Given this list of marker genes DEXI, SOSTDC1, ANKRD13B, LINC03020, CPLANE2, SELENOM, EPS15, MARCHF3, FGD5P1, ITGB1, SEMA3B-AS1, TSC22D1, ZYG11B, RPS6KA1, HMGB1P28, EIF2AK3-DT, CHAC1, B4GALNT1, JMJD4, EPHX1, ENSG00000187951, ALKBH5 (alkB homolog 5, RNA demethylase), MIDEAS, HNRNPH3, MPP2, SLC25A28, SPSB1, NAV1, USP35, TMEM164, MIR22HG, PRCC, NFIX, INPP5A, DOCK7, ARPIN-AP3S2, TNK2, TMEM74, MINDY2, RFPL1S, NEDD4L, AGA, COPS7A, RAN, ZFTA, SP3, POLA1, VASN, CHP1, TMT1A, COLGALT1, USP10 (NCBI Gene Id 9100), LEPROT, WDR5, CCNG2, GATA3-AS1, CNOT10, KCTD11, SEC1P, PRICKLE1, RRAGB, IQCF5-AS1, SLC29A4, NUCB2, SERTAD3, MOCOS, BACE2, WWC2-AS1, DIO1, WFDC21P, EHMT2, TCP10L, LMO2, CYTH1, E2F3, PDIK1L, NBPF11, LINC02391, GALE, SDAD1P1, TMEM145, UGGT2, LETMD1, ZNF76, CCL24, CDIPT, LARP1, MYO9A, GP9, PTGES2 (NCBI Gene Id 80142), VSTM2L, TK2, EIF2AK3, CALR, GFI1B, TELO2, FAM13A, SHB, BSG, ARHGAP33, S100A16, DONSON, PROSER2, ERRFI1-DT, SUB1, PHOSPHO1, TMEM245, FGGY, ANO5, ENSG00000266976, KCNN1, UTS2B, HAUS2, PYM1, EFCAB7, KTN1-AS1, MACF1, PARD3B, NKILA, MKLN1-AS, ZNF44 (zinc finger protein 44), PFDN4, AP3B2, TMEM140, IER2, ZNF628-DT, EPM2A-DT, RNF227, C2, SLC25A22, AKR1B1, PICART1, TCN2, MMAA (metabolism of cobalamin associated A), MCUR1, SULT2B1, DOK4, KLC4, FBXO2, DGKA, FAM222A-AS1, DPF3, CACNG7, UBALD1, TMEM167A, ENSG00000233230, MRAS, ZNF256, TEX2, TM2D1, TFDP1, ZSCAN5A-AS1, ZBTB7A, GHDC, REM2, NCS1, GAL3ST1, DUSP7, VAT1, ASCC2, UBASH3B, B4GALT5, PEX19, ITPK1, DHRS12, SLC25A28-DT, SPPL2A, MIEF2, MAP3K12, ZNF548, TYW1, CCN1, METTL26, SLC6A9, SPN, TNFRSF12A, PHLDA1-DT, MAP3K7, MBOAT7, SREBF1, CLDN5, INTS6-AS1, EFHD1, COX10, CD2BP2, RNF44, TBKBP1, EP400P1, ZFAND3, POGK, ENSG00000267288, SBDS, KPNA6, FBXO11, TAL1, TLE4, SDSL, KIAA0930, CKLF, POC1A, CTNNBIP1, SLC39A8, MRPL55, CHRNA1, ATXN7L1, TMC6, SARDH, AP4M1, ILVBL, USP36, BPIFB6, INKA2-AS1, RBMS2, RBM39, ADCK1, PALD1, BPNT2, SLC35D1, C5AR1, SURF4, NPY1R, DMAC2, ASH2L, TNRC18, OTOG, KTN1, BTF3L4 (basic transcription factor 3 like 4), HIPK2, ASL, RYK, SNX32, IQANK1, ERICH6, ENSG00000283573, ETFBKMT, POLR1G (RNA polymerase I subunit G), ADRA1A, C19orf25, ADRB3, SQSTM1, TMED1 (NCBI Gene Id 11018), RGS16, HIVEP3, SUPT7L, TMUB2, FBRS, YJU2B, SATB2, SMG1P2, IRGQ, B2M, SUGCT, ENDOG, GNB1 (NCBI Gene Id 87729), IKBKB, PUSL1, FNIP2, CHD4, PPP1R13L (NCBI Gene Id 23453), MMP17, EPB41, PAPOLA, RPSAP71, YRDC, CYP27B1, NKD2, KLK8, HES1 (NCBI Gene Id 3280), ETF1, HDGF, KLHL5, FAM182B, EXPH5, PPP1R14B-AS1, PIK3C3, PAFAH1B2, TATDN1, NAV3, SYTL4, ACTL6B, ARHGEF12, DLG3 (NCBI Gene Id 89363), SLC26A6, CS, ZNF416, ZKSCAN8P1, CCDC28B, ZNF524, POLI, FUNDC1, OR52A4P, RNA5SP319, ZNF703, MVP, LSM12, CRYGEP, CYP4B1, INCA1 (inhibitor of CDK, cyclin A1 interacting protein 1), GAN, GALNT11, RFT1, HES2, ADPRHL1, LIM2-AS1, SLC4A11, AXL, PLD1, MAPK8IP1, ENSG00000266088, SEC22C, CYRIB, VASP, RTN4IP1, PJVK, OSBPL5, ENTPD7, ASAP2, RNASET2, DUS1L, TMEM184B, LINC02405, NUMA1 (NCBI Gene Id 4926), SAXO5, PLBD2, OTUD7A, LINC01825, XIST (X inactive specific transcript), ZFP91-CNTF, MIF, VPS37D, WDR5-DT, SPACA6-AS1, NFIB, C10orf88, LINC02573, SLC25A23, TAF6L, MAGI1, PCGF6, RGS10, MRPL39, YARS1, DSTYK, TWSG1-DT, ACAP3 (ArfGAP with coiled-coil, ankyrin repeat and PH domains 3), SLC25A46, TMEM120B, SPATA41, BAZ2A, DNAJC8, TMEM236, TMEM119, MICAL3, MKI67, CFP, RNASEK, ETHE1, OTUB2, VAMP4, AHCYL2, ROBO1, USP45, IFT43, ANKRD10, ZFP69, NBAS, SHKBP1, HCFC1, CIRBP, ARHGEF19, GIT1, ANKMY1, MAMLD1, RPS6KL1, NFATC4, IGKV6D-41, C1orf122, ERCC1, CECR7, SNED1, RPL10P8, LINC01366, MSH5-SAPCD1, DNAH9, RPL12, PRPH (NCBI Gene Id 5630), AMER1, NKX3-2, ASB16-AS1, ANLN, ZNF547, TMEM160, TUBAP14, MRPL44, POC1B, GNB4, AGA-DT, ZFAND6 (zinc finger AN1-type containing 6), RNPS1, IQCH-AS1, PAN3-AS1, GJD3, FLNA, ITPRIPL2, MAPRE2, FAM234B, NFIA, SEPHS2, MORC2, EEF1A1P7, GIT2, GPAM, IFT81, NPM3, MKNK1 (NCBI Gene Id 8569), RND1, ZKSCAN3, FBXO5, GMFB, VASH1-DT, CYP19A1, LINC01625, LMAN2L, LINC00540 (long intergenic non-protein coding RNA 540), RBM44, DNAJB1, ATG2A, TCF7, SUCLG2, CASP8, LINC02028, ZNF792, ATOH1, TRAPPC2B, RPL23AP53, ZNF436-AS1, AACS, UBE2F-SCLY, C2orf92, MIR550B1, RPL17P41 (ribosomal protein L17 pseudogene 41), IKBKB-DT, RTCA, DAGLB, STX5-DT, SH3BGR, MRTFB, GIPC1, NEK6, XPR1 (xenotropic and polytropic retrovirus receptor 1), JPH4, FBXO9, SLC25A12, FKBP8, EBI3, RFNG, PICALM, CACNA1A, CSPG4, AHDC1, DPP9, MIR3677HG, MAPKAPK2, EGFEM1P, EMSY (EMSY transcriptional repressor, BRCA2 interacting), PMEPA1, LRFN3, EEF1AKMT3, RIC8A, XRCC4, ADNP, KDELR2, CRADD-AS1, MCEMP1, TKT, CAMKK2, KDM4C, BPTF (bromodomain PHD finger transcription factor), TRA2A, DNAJB5-DT, MEF2D, GCN1, ANO10, ATXN2, MVP-DT, DNAJC16, ZNF596, EWSR1, STX3, LRRC23, CBLN1, ACTN2, TRAPPC8 (NCBI Gene Id 373175), SSR4P1, ECT2, MIA2, HEXIM1, BTBD2, FAM131A, TXNDC17, CKAP5, ACBD3-AS1, SLC25A53, METAP1 (methionyl aminopeptidase 1), FLII, FCHO1, PITX1, TOM1L2, KIF6, RAB11A, RPL21, GOLGA3, NRL, SLC16A3, MRPS17, TMEM198B, FAM149A (family with sequence similarity 149 member A), ZNF48, YIPF1, MKLN1, HDLBP, TEN1-CDK3, TAOK3, KSR1, SLC9A9, TUBAL3, ZNF623, MRPL42P1, PSME4, ERVV-2, BRD3OS, CHPF, LINC02593, BBS10, USP2, IER5, RPL29P34, DCUN1D2, MEIS3, CDC14A, RPP14, C19orf73, CSF2RB, SPRY1, ADORA1, UBAP2L, TRAF3IP2-AS1, UNC13A, CRELD1 (cysteine rich with EGF like domains 1), DIPK2A, KDM6B, ABCA7, NOS2P4, LINC02926, DUSP8, KCTD21, TMEM39B, MCRIP2, RPL7A, ADARB1 (adenosine deaminase RNA specific B1), DNAJC6, BAZ1B, CASTOR1, LINC00690, ANP32E, BICRA, PROSER2-AS1, MARK4, RPN2, PRR14, PEX5, ZNF576, CCDC47, MSH5, LINC00115 (long intergenic non-protein coding RNA 115), EPOP, PCSK7 (NCBI Gene Id 95070), ATOH8, C19orf38, PRRT1, ZMYM4, NAA25, HES6 (NCBI Gene Id 94875), WIZ, KCNIP2-AS1, MOB3C, LINGO1-AS1, SYNCRIP, SPATA24, C1orf43, DOCK7-DT, KLHL25, B4GALT1-AS1, CFAP91, ALDOA, CCT7 (chaperonin containing TCP1 subunit 7), WRAP73, EIF3H, ING2-DT, TBC1D13, MCM7, ZNF683, GLT8D2, PRKAG1, EFCAB14, MED11, SHISA5, RASA4DP, PRSS33, STK36, MYLK, ZNF575, NFKBIE, ABHD6, SRSF9, BDNF-AS, LRP4-AS1, TSPAN3, MED13L, THAP9-AS1, ARHGDIB (Rho GDP dissociation inhibitor beta), FCSK, RERE, IBA57, CSNK1E, IRF2BP1, PCF11, SYPL2, PRPF8, CATIP, TRAPPC14, OR4K5, GUCY2C-AS1, MBD5, FBXO44 (F-box protein 44), UBALD2, TMX2, CPEB1, SH3PXD2B, QRICH1, ENSG00000235978, NIFK, TRMT2A, FLAD1, HOMER1, ST3GAL3, LENG9, LINC00881, MECOM, ERGIC1, INIP, TTC21B, ABHD8, TRAPPC9, PLEKHH1, P2RX6, RAB11FIP1, CCDC160, NR3C2, PORCN-DT, AGO3, ZNF551, MIR3197, ALOXE3P1, FNDC11, NEU1, REEP4, DCXR-DT, OXR1, DPAGT1, CALN1 (NCBI Gene Id 83698), USF3, MROH8, GNS, KIF1C, ENSA, PAPOLA-DT (NCBI Gene Id 731887), WDR89, GNA12, DLG2, FAM43A (NCBI Gene Id 131583), VEGFD, MAIP1, C6orf136, CPEB1-AS1, SNPH, PRKAR1A, SOX5, SCP2, SMAP2, STX2, CEP128, CEP250, RHOC, COTL1, SGK3, HNRNPL, DERL1, AKT2, MED22, ITM2C, SREBF2, ETV3 (ETS variant transcription factor 3), ABCD3, BOLA3-DT, MPZL1 (NCBI Gene Id 9019, myelin protein zero like 1), METTL21A, SERPINF1, CCDC9, MOB3A, CRTC1, CNNM4, DBP, PLP1, NIPSNAP2, MPP1, APOBEC3B, LRP6, WASH3P, RFX5, TEKT4, FER1L4, GPS1, EFCAB11, KLRK1-AS1, EN2, ZFAND3-DT, ATXN1-AS1, ZNF581, CFAP157, HPS3, CACNG5, ADAMTSL5, KRTAP5-AS1, TXNDC12, BCRP8, PTMA, SYT7, ZBTB47-AS1, RGS12, YWHAEP7, ZNF408, ZNF609, YOD1, MAP3K11, B4GAT1, AHCY, GGA1, ENPP6, DYSF, UQCC6, TTC23, APRT, LINC00896, MIR4726, ADGRB2, PI4KA, PSMD9, DCAF11, TUBA1C, ESF1, BDH2, MINDY2-DT, SLC27A1, TWSG1, PNPO, ZSCAN5A, PSTK, MIR548AW, PROCA1, FRYL, SEC13, ZSWIM4, SAMD13, TYW5, CLN3, NBPF1, VAPA, LMBR1L, ZNF275, TENT5B, EGFR-AS1, ARHGEF1, SAMMSON, MLLT6, CHD9NB, RBM23, FBXO24, TRIM21, LRATD2, RHOD, PPP1R14B, PRPF39, LMNA, RN7SL466P, MYH10, PLA2G6, SMARCA2, FOXN4, PCYT1B-AS1, POP5, LANCL1, MAFG, SPATC1L, ZNF12, CREB3L1, UPP2, ABCG4, TRIP10, PRMT3, G3BP1, HAPLN3, SMARCB1, RBPMS2, POC1B-GALNT4, NCOR2, SIDT2, SPACA6, SRP54, VDAC1P13, SSBP4, HAPLN4, RN7SL774P, MMP15, CCNH, ITGA3, MB21D2, UTP23, PRDM1, SMYD2, HYAL2, SFXN5, SLC25A37, CFDP1, POLR3E, POU2F1, AIFM1, SNHG12, LSR, RMND1, PHLDA1, ARRDC4, KMT2A, SUCLG2-DT, TLCD3B, NAA60, ADCY6, SEMA4C, VGF, RBBP4 (NCBI Gene Id 91125), PTGES2-AS1, PRKD2, BCR, SEC14L1, GTF2H1, MRRF, NR2F2-AS1, SEC31A, AGO2, SLC2A4 (solute carrier family 2 member 4), INTS6, RAD51AP1P1 (NCBI Gene Id 100420047), GSE1, INPPL1, MAP1S, LRIG1, DLG1, P2RX3, MPLKIP, TMEM241, GLRX, POLG2, YPEL5, FAM117B, DNAJC10, C5orf47, ZBTB7C, DOHH, METTL1, LRCH4, CDK4 (cyclin dependent kinase 4), SLC22A17, SETD2, KCNK7, DGLUCY, UBE2I, FIS1, TRRAP, GATA3, EIF2B4, ZNF644, ARMC9, CAPS2, ADCY6-DT, EFNB1, MGAT4B, ANO6, TMEM37, FAM230C, ABR, STX16, PTPN21, CLDND1, RAMACL, SIGLEC6, LRRC8A, PRR14L, PEX11B, SLC39A13, THUMPD2, PDE2A, DGUOK-AS1, ELMO2, ARPIN, LINC01094 (long intergenic non-protein coding RNA 1094, NCBI Gene Id 101928893), NDUFB9, PACSIN2, KIF9-AS1, ENSG00000248161, DUSP19, CSRP2, IFNAR2, LTK, PISD, TRIM65, DNAJC25-GNG10, IL18BP, DEUP1, RARA, GGT1 (gamma-glutamyltransferase 1), C19orf53, SLC35C1, ASAH1-AS1, CBX6, PIK3CB, PPP1R18, ZBTB12, L1CAM-AS1, ZDHHC23, GNRHR2, ETV5, ENSG00000282904, ITGB3BP, RAP1A, PPFIA3, PIGR, MAT2B, ARHGAP1, RNASEK-C17orf49, TMEM232, C2CD2L, CERCAM, KIAA0753, ERF (NCBI Gene Id 2077), ESRRB, NR2C2AP, RHOQ, B4GAT1-DT, FBXW7, CSNK2B, NOL12, ZNF700, RTCA-AS1, FZD9, REXO2, ENSG00000237654, NBPF3, LINC00847, USP30, ACOT13, SORBS1, PSD2, DIDO1, TMED10, MIR607, GTDC1, SEMA6C, FLNC-AS1, DENND4B, MGST1, NFYC, NOS3, FIZ1, RPL35A, SERTAD2, TRMT10A, COQ8B, XXYLT1, SRF, ECI1-AS1, BICRA-AS2, LRSAM1, ETV6, SNHG20, KPNA2, ABCC12, UBR5, ITIH1, LINC02643, AGPAT4, TMEM143, POLR2B, HOXC13, VPS51, ACSM1 (NCBI Gene Id 116285), RFC2, SUMF1, ATP8B1-AS1, ERICD, SPRY4, IZUMO4, LINC01132, TLCD4-RWDD3, TSHZ2, HERPUD2, CCS, TDP1, PPP1R14C, BORCS8, SETP16, CDC37, TDP2, GON4L, GABBR1, TBXAS1, GTF2A2, MTTP, MIA2-AS1, NKX2-5, TOLLIP, ARMT1, RBM18, GYPC, UVSSA, CSK, LCORL, SCARNA16, EARS2, KHDC4, TRIB1, MICAL2, HOXD8 (homeobox D8), FEZ1, SOHLH2, OSR2, ZNF668, HMGB3, SERGEF, ANAPC7, BBC3, RANBP1, TAGLN2, ABI1, ARID3A, RPL23AP8, CDC25B, PCNX3, NME3, NR2F2, MAST1, SYCP2L, MAP4K2, C1R, SNX8, MCOLN1, THBS3-AS1, UBE2V1, YBX3, ZBTB22, PBX1, ASAH1, UBE3B, TMEM176B, BRPF3, CCAR2, COL1A1, RBM27, ENSG00000282936, KCTD3, TNRC6B, RAB30, CPS1, LINGO1, UBFD1, EPHA1, RBM15, F8, RFXANK, RASSF5, CENPJ, SRGN, YTHDC2, TMCO3, RGS9, ZMYM3, OSGIN1, COX6B2, DIAPH2, CASP8AP2, DCAF10, ZFP64, SANBR, CPD, PIAS3, NBPF12, ZFX, BORCS5, IDI1, GATAD2A, LHX6, LINC01128, CASC11, BICRAL, NABP2, TDG, ATP6V1G2-DDX39B, H2AX, TTC39A, NBPF9 (NCBI Gene Id 400818), ETS1, TSC1, HBP1, NFIC, IFFO2, ARRDC3, PRKCSH, WDSUB1, TULP2, PPP2R5B (NCBI Gene Id 5526), ARFGEF1, DCTD, SCNN1A, LY6S-AS1, RNU6-992P, IKBKE, ANKFN1, GBA2, LMBR1, BORCS8-MEF2B, WDR37, ACTR1B, DDX42, MAPKAP1, FZD2, SEMA3B (NCBI Gene Id 7869), KCNH3 (NCBI Gene Id 23416), IREB2, LMCD1 (NCBI Gene Id 29995), HIBCH, ZBTB8OS, MIGA2, LAT, PAN3, INKA2, SEPTIN9, REXO1 (RNA exonuclease 1 homolog), PIAS4, METAP2, TLCD4, AXIN2, ING2, ZBTB8A, ZFAND5, MSLNL, TOPBP1, CASP9, RPE, VPS9D1, ARPC5L, PHF23, LINC02356, BCL9, PES1, SNAP29, FBXL7, LINC00680, KCTD10, HTATSF1, KIAA2013, LINC02575, TRPV6, PLAT, CPB2-AS1, CECR2, TPRA1, EXOSC7, MAPK14, NATD1, ZNF672 (zinc finger protein 672), SEMA6B, UBE2D2, HIBADH, TMEM91, DENND3, JAK2, ADH5, XPO7, PFKP, ZNF564, MLXIP, LMCD1-AS1, NBPF15, RO60, ADGRG1, HSP90AB1, RNY3, DCBLD1, SH2D6 (NCBI Gene Id 284948), DNAJC25, ACSM3, TRPS1, MTMR11, SOCS2, IKZF4, ENSG00000245651, TAPT1 (NCBI Gene Id 202018), MEIS1, GPR158, STK35, NASP, ATXN1, CDK18, CTNNA3, BCL9L, COL16A1, CCP110, MAU2, KRT8, LINC01690, RBL1, PHPT1, PPP1R14A, HDAC5, VASH1, KLC3, CEPT1, LGR6, MAP3K4, ZFP91, CCDC85C, ERICH6-AS1 (NCBI Gene Id 101928085), ORC4, FMO5, MTERF2, ITPKC, TBCC, SF3A3, NICN1, SPIN1, PMP22, STX16-NPEPL1, CHMP4A, RPL7AP77, TSPAN31, SNAP47, AQP8, YPEL2, DDX53, POLDIP3, LEPR, AURKAIP1, SNUPN, NUP58, VPS9D1-AS1, FER, ERRFI1, GNB1-DT, FOXO4, PER2, PUS7L (pseudouridine synthase 7 like), LINC00630, SRRM5, GNL3L, STX5, ATP6V1F, GSTO1, IGFBP6, CENPE, CENPM (NCBI Gene Id 79019), REV3L, KRT222, ANGEL2, RELA, EIF2S3, BICD1, PELI2, EPC1, CEP85L, NBR2, HERPUD2-AS1, PTGR3, HMG20B, TMEM123, EMC9 (ER membrane protein complex subunit 9), GXYLT2, DNAJB5, KANSL3, ZMYM6, SIGLEC22P (sialic acid binding Ig like lectin 22, pseudogene), KCTD8, SLC8B1, ST3GAL2, OAF, LINC01962, IFITM9P (interferon induced transmembrane protein 9 pseudogene), IRAG1 (NCBI Gene Id 30831), MILIP, DCXR, USP22, MRPS2, SP2-AS1, CCNB3, STKLD1, PBX2, EXD1, FBLN7, LRRC51, MRTFA, RCAN1, AAAS, RABGGTB, MRPL2, TSC22D4, SZRD1, TSC22D3, GPR63, CITED1 (Cbp/p300 interacting transactivator with Glu/Asp rich carboxy-terminal domain 1), LINC01182, PTPRS, SMAD6, UBE2E2-DT, KYAT1 (kynurenine aminotransferase 1), TBCK, COMMD8, CDIPTOSP, PCM1, GRHL1, SUGP1, PAK4, TUBBP9, SNX12, CYTH2, E2F2, USP49, PRMT5-AS1, ATP6V1G2, PTPN4, NUCB1, PRKRA, MSL1, LINC02615, MGRN1, CNPY2-AS1, CARF, TARS2, ASMER1, DVL3, SND1, MRM1, DYNLL1, HIF1AN, TRIM44, LINC01665, HTD2, TXNDC11, ARHGEF2, EDEM1, ZNF684, PSEN2, AMBRA1, BRPF3-AS1, RANGRF, ANXA2R-AS1, ENSG00000275740, CRTAP, PHRF1 (PHD and ring finger domains 1), PTPN1, DNAJC14, ITPRIPL1, PNPLA6 (patatin like phospholipase domain containing 6), ZC3H13, ESAM, SARAF, CDK3, CFAP46, PLA2G4C (phospholipase A2 group IVC), SLC44A2, ZFAND1, GAS2L1, CLIC2, LPIN1, HROB, PATL2, UBE2F, ZNF865, HEMK1, TMEM187, POGZ, WDR43, EN2-DT, PHETA1, NRXN3, SLC4A1AP, OGA, DDX10, TMEM248, PCAT6, ABCA4, SNORD45C, LIG3, CLUH (clustered mitochondria homolog), TCP11L2, VPS8, PI4K2A, RNVU1-15, LCNL1, NFKBIL1, SLC12A5, IQCG, ANKRD24, AOX1, NBEAL1, PPP4R3A, ACTL8, LINC02419, INPP5J, WDR81, ADGRD1, UHRF2, IPO8, PIEZO1, PDXK, LPXN, ZNF783, ATG5, SUSD6, PORCN, ELP3, MAPKAPK3, SEC14L2, SNORA70J, ANKRD17, GMEB1, UBE2N, CYP1A1, ISLR, TMEM198, NSMAF, NMUR1, GMEB2, IRAK4, ACVR1, MNT, CLIC1, SLC9A6, CLDN6, MIR762HG, VKORC1L1, IL1R1, PIERCE1, UBE2E2, SMARCA4, NEBL, here is a description of the gene set: from publication Yevshin I, Sharipov R, Kolmykov S, Kondrakhin Y, Kolpakov F (PMID 30445619) Genes containing one or more binding sites for (ZFP91) in their promoter regions (TSS -1000,+100 bp) as identified by GTRD version 20.06 ChIP-seq harmonization. studied in species Homo sapiens Human Gene Set: ZFP91_TARGET_GENES